Given this list of marker genes KCNQ1, TLR8, LILRA1, PTAFR, EPB41L3, SLC15A3, UBE2D1, LILRB2, PSAP, VDR, GASK1B, HNMT, VCAN (versican), PILRA, LILRB3, NOD2, IFNGR2, CD86, TYMP, RASSF4, GNS, EFHD2, SMPDL3A, SIRPAP1, CAMK1, TFEB, STS, LILRB1, SIRPB1, MAFB, SIGLEC7, CCR1, here is a description of the gene set: BACKGROUND: In patients with acute myeloid leukemia (AML) a combination of methods must be used to classify the disease, make therapeutic decisions, and determine the prognosis. However, this combined approach provides correct therapeutic and prognostic information in only 50 percent of cases. METHODS: We determined the gene-expression profiles in samples of peripheral blood or bone marrow from 285 patients with AML using Affymetrix U133A GeneChips containing approximately 13,000 unique genes or expression-signature tags. Data analyses were carried out with Omniviz, significance analysis of microarrays, and prediction analysis of microarrays software. Statistical analyses were performed to determine the prognostic significance of cases of AML with specific molecular signatures. RESULTS: Unsupervised cluster analyses identified 16 groups of patients with AML on the basis of molecular signatures. We identified the genes that defined these clusters and determined the minimal numbers of genes needed to identify prognostically important clusters with a high degree of accuracy. The clustering was driven by the presence of chromosomal lesions (e.g., t(8;21), t(15;17), and inv(16)), particular genetic mutations (CEBPA), and abnormal oncogene expression (EVI1). We identified several novel clusters, some consisting of specimens with normal karyotypes. A unique cluster with a distinctive gene-expression signature included cases of AML with a poor treatment outcome. CONCLUSIONS: Gene-expression profiling allows a comprehensive classification of AML that includes previously identified genetically defined subgroups and a novel cluster with an adverse prognosis. Top genes from cluster 5 of acute myeloid leukemia (AML) expression profile; 96% of the samples are FAB M4 or M5 subtype. studied in species Homo sapiens from publication Valk PJ, Verhaak RG, Beijen MA, Erpelinck CA, Barjesteh van Waalwijk van Doorn-Khosrovani S, Boer JM, Beverloo HB, Moorhouse MJ, van der Spek PJ, Löwenberg B, Delwel R (PMID 15084694) Human Gene Set: VALK_AML_CLUSTER_5